Given this list of marker genes TPCN2, NF1, MREG, SLC45A2, FIG4, BLOC1S5, LYST, SZT2, EDNRB, HPS3, MYO7A, POMC, ANKRD27, EDNRA, VPS33B, CITED1, BLOC1S6, MC1R, SHROOM2, RACK1, ZEB2, ADAMTSL4, MITF, GNAT1, RAB29, SNAPIN, BACE2, AP3S2, RAB17, MLPH, TBX2, ASIP, RAB11B, PIKFYVE, SNAI2, DCTN1, GNAT2, KITLG, OCA2, EN1, BLOC1S4, BCL2L11, RAB27A, BCL2, KIF13A, MAP2K1, EDAR (ectodysplasin A receptor), ATP7A, MFSD12, USP13, AP1S1, OR51E2, TYR, GPR143, MKKS, AP3B1, HPS1, BBS5, DTNBP1 (NCBI Gene Id 84062), DCT, APOE, LRMDA, RAB11A, TH, MYSM1, PMEL (premelanosome protein), ARCN1, CDH3, EDA, HPS6, HPS4, ADAMTS9, ATRN, AP3D1, RAB32, KIT, AP1S2, AP1B1, BLOC1S1, AP3S1, HPS5, AP1M1, RAB1A, VANGL1 (VANGL planar cell polarity protein 1), GLI3, AP1G1, SPNS2, DRD2, CD63, IHH, ATP6AP2, ENPP1, EDN3, MYC, BAX, MEF2C, AP3M1, SOX10, ARL6, DCTN2, RAB38, BLOC1S3, VPS33A, TYRP1, AP1S3, KRT76, SOD2, MYO5A (NCBI Gene Id 4644), ADAMTS20, SHROOM3, ABCB6, BBS7, GNA11, BLOC1S2, BBS2, here is a description of the gene set: Human Gene Set: GOBP_PIGMENTATION The accumulation of pigment in an organism, tissue or cell, either by increased deposition or by increased number of cells. studied in species Homo sapiens